Given this list of marker genes RB1, CEBPA, MED17 (NCBI Gene Id 9440), H2AC6, MED20, KMT2A, H4C16, H3C3, PEX11A, H4C14, NCOR2, H2AZ2, PLIN2, CD36, H2BC15, MED16, MED4, H4C1, H2BC7, MEN1 (menin 1), LPL, H3C8, GPAM, H2BC14, NCOA3, HCFC2, GPS2, LPIN1, MED1 (NCBI Gene Id 9327), H3C13, ACSL1, LIPE, H3C2, H3C7, H2BC9, H2BC17, EP300, KANSL3, CIDEC, TBL1X, H3-3A, H2AJ, NCOA2, ASH2L, H3C15, H2AC4, MED30, MED23, KAT14, BOD1L1, SETD1A, H4C3, MED31, CCNC, ANGPTL4, H2BC3, H4C2, MED27, WDR82 (WD repeat domain 82), FABP4 (fatty acid binding protein 4), MED6, H2BC4, H4C5, BOD1, PHF20L1, CDK5, ZZZ3, KANSL2, KMT2B, PSIP1, H2BC12L, NCOA6, H4C8, H2BC1, H2BC13, H2BC5, KAT2A, SETD1B, H2BC8, MED12, SIRT1, H3C11, MGLL, PPARG, HDAC3, H3C14, H2BC10, PLIN4, H2AC20, MED14, H2AC18, H2AX, PPARGC1A, DPY30, RBBP5, MED13, H3-3B, TADA2A, YEATS2, RXRA (retinoid X receptor alpha), ABL1, WDR5, H2AC8, MBIP, SCD5, KAT2B, H4C4, CDK8, H4C6, MCRS1, HCFC1, H2BC11, H2BC6 (H2B clustered histone 6), PAXIP1, H2AC14, H4C12, AGPAT2, H2AB1, PNPLA2, H3C4 (H3 clustered histone 4), PHLDA1, TASP1, H3C10, H3C1, AJUBA, H4C11, H3C6, PDK4, NCOA1, NCOR1, ADIPOQ, NCOA4, H4C13, THRSP, PAGR1, PLIN1, CREBBP, DGAT2 (NCBI Gene Id 84649), KMT2C, H4C15, MED10 (NCBI Gene Id 84246), OGT, ELOVL5, H2BC21 (NCBI Gene Id 8349), TBL1XR1, SGF29, H2AC19, KMT2D, MED24, CXXC1, TADA3, KDM6A, DR1, MED7, PHF20, KAT8, SCD, H4C9, H3C12, AKAP8L, H2BC26, PPARGC1B, H2AC7 (H2A clustered histone 7), ACSS3, KANSL1, H2BC12, here is a description of the gene set: studied in species Homo sapiens Human Gene Set: REACTOME_EPIGENETIC_REGULATION_BY_WDR5_CONTAINING_HISTONE_MODIFYING_COMPLEXES Epigenetic regulation by WDR5-containing histone modifying complexes